The following is a description of a gene set: Reactome Pathway: RUNX1 regulates transcription of genes involved in interleukin signaling part of: Transcriptional regulation by RUNX1 This event has been computationally inferred from an event that has been demonstrated in another species.<p>The inference is based on the homology mapping from PANTHER. Briefly, reactions for which all involved PhysicalEntities (in input, output and catalyst) have a mapped orthologue/paralogue (for complexes at least 75% of components must have a mapping) are inferred to the other species. electronically inferred by orthology from the curated human pathway studied in species Mus musculus, and this is the list of marker genes: Cbfb, Elf1